The following is a description of a gene set: Mouse genes annotated to increased incidence of tumors by chemical induction (MP:0004499) retrieved from the Mouse Genome Informatics database via MouseMine species: Mus musculus from publication Motenko H, Neuhauser SB, O'Keefe M, Richardson JE (PMID 26092688) Mouse Gene Set: MP_INCREASED_INCIDENCE_OF_TUMORS_BY_CHEMICAL_INDUCTION, and this is the list of marker genes: Nlrp6, Ahr, Bin1, Mir34a, Chek2, Ptgs2, Gpa33 (glycoprotein A33 transmembrane), Map3k6, Xpa, Folr1, Rassf1, Bub1b, Ncoa3, Pms2, Ppp2r1a, Lox, Klf14, Trp73, Irf1, Stat3, Tgfbi, Aldh2, Fhip2b, Pparg, Stk26 (serine/threonine kinase 26), Thbs2, Ski, Mxi1, Fgfr2, Skil, Ppp2r5a (protein phosphatase 2, regulatory subunit B', alpha), Slc7a11, Etv6, Nlrp12, Wwox, Gnai2, Taf4, Flcn, Elavl1, Ceacam1, Rae1, Uaca, Il22ra2, Ppargc1a, Hint1, Errfi1, Ppard, Cuedc2 (CUE domain containing 2), Trim16, Il22, Dek, Chfr, Usp24, Dusp5 (NCBI Gene Id 240672), Fhit, Trpv1, Cebpa, Ercc2, Poli, Bap1, Atg4c, Cul9, Cyp19a1, Ranbp2 (RAN binding protein 2), Foxm1, Ptprt, Ifnar1, Apc, Tert, Tnfsf10, Bub1, Adamts18, Rnf20, Tsc1, Uimc1, Trex2, Dnai7, Nfe2l2, Habp4, Paqr3, Stk38, Vhl, Mir203, Epha2, Fam3d, Klf10, Egr1, Runx1, Cep57, Rhob, Cdkn2a, Bub3, Mif, Ralgapa2, Fos, Klf4, Anp32b, Ltf, Msh2, Stk11, Mapk8, Mir139, Pten, Yap1, Cat, Akr1b8, Fpr2, Ptpn11, Bcl2l14, Cyld, Mbd3, Ttll3, Retnlb, Cygb, Cdkn1a, B3gnt6, Pard3 (par-3 family cell polarity regulator), Cd226, Trp53 (NCBI Gene Id 22059), Trp53inp1, Nmi, Il12a, Nit1, Ip6k2, Plcl1, Map3k8, Grhl3, Cav1, Ifnar2, Map9, Tgfbr2, Ppp6c, Cdkn1b, Gast, Chordc1, Prkch, Il9, Sf1 (splicing factor 1)